Given this list of marker genes Ltc4s, here is a description of the gene set: part of: Biosynthesis of DHA-derived sulfido conjugates studied in species Mus musculus electronically inferred by orthology from the curated human pathway This event has been computationally inferred from an event that has been demonstrated in another species.<p>The inference is based on the homology mapping from PANTHER. Briefly, reactions for which all involved PhysicalEntities (in input, output and catalyst) have a mapped orthologue/paralogue (for complexes at least 75% of components must have a mapping) are inferred to the other species. Reactome Pathway: Biosynthesis of protectin and resolvin conjugates in tissue regeneration (PCTR and RCTR)